Given this list of marker genes PTGER4, FLT4, ULK4, IRAK4, APP, NR2C2, PAFAH1B1, LTBR, TAOK1, CRK (NCBI Gene Id 1398), EDAR, MTURN (NCBI Gene Id 222166), TNFRSF11A, TNIK, MAP4K1, MAPK9, TLR3, SH2D3A, DUSP19, MDFIC, ANKRD6, GPS1, CBS, MAP3K13, MYD88, CCL21, EDA2R, PRMT1, NFKB1, FGF12, FZD10, STRADB, NAIP, SIRPA, MAP3K6, LRRK2, GADD45G, WNT5A, CCN2, TRAF2, HRAS, GRIK2, PHLPP1, SEMA3A, MAP3K15, FKTN, MDFIC2, MYOC, MAP4K3, TAOK3, EPHA4, FZD7, CCL19, AGER, MINK1, MEN1, TLR7, EDN1, HIPK2, IRAK1, TNXB, GSTP1, MAP4K2 (mitogen-activated protein kinase kinase kinase kinase 2), MIR92A1, UNC5CL, SLAMF1, EPHB1 (EPH receptor B1), NOD2, PDCD4, DVL2, MARVELD3, TAOK2, TLR9, PTK2B, CARD9, CDC42EP5, PLCB1, WNT16 (Wnt family member 16), MAPKBP1, ZNF622, MAP2K4, TPD52L1, RASSF2, RIPK1, DUSP10, ARHGEF6, TNFRSF19, ATF2, MAPK8, BIRC7, NOX1, MDFI, ITCH, TNF, SH2D3C, MBIP, AIDA, TRAF6, SERPINB3, MAP2K7, MAPK8IP1, PINK1, NRK, CRACR2A, STK3, JUN, DACT1, PYCARD, NPPA, HIPK3, WNT7B (Wnt family member 7B), TRAF4, CCDC88C, SERPINF2, PJA2, NPHS1 (NPHS1 adhesion molecule, nephrin), HACD3, MAP1LC3A, F2RL1, MAPK10, MAP3K12, MAPK8IP3, PER1, MAP3K7, PRKN, RB1CC1, RIPK2, MFHAS1, TRPV4, DKK1 (NCBI Gene Id 22943), ERCC6, GADD45B, DUSP22, COPS5, RNF13, DAB2IP, TIRAP, IGF1R, DVL3, CD27, GADD45A, MAP3K20, XIAP, CYLD, MAP3K10, TGFBR3, FGF19, KLHL31, SH3RF2, HMGB1, DAXX, TRIB1, FCGR2B, SH3RF1, TLR4, FGF14, ZMYND11, ENSG00000274276, RAP2A, MAPK8IP2, DUSP9, DNAJA1 (NCBI Gene Id 4737), SDCBP, NCOR1, ZNF675, MECOM, PTPN22, TNFSF11, GPS2, SH3RF3, IL1B, DUSP3, CCR7, MAP3K5, CRKL, SMAD3, WNT7A, AXIN1, MAP3K11, HDAC3, CASR, MAP4K4, BECN1, NOD1, RGS2, AMBP, here is a description of the gene set: studied in species Homo sapiens Human Gene Set: GOBP_JNK_CASCADE A MAPK cascade containing at least the JNK (MAPK8) MAP kinase. It starts with the activation of JUN3K (a MAPK3K), which activates JNKK a MAP2K), which in turn activates JNK. The cascade can also contain an additional tier: the upstream MAP4K. The kinases in each tier phosphorylate and activate the kinases in the downstream tier. The JNK cascade is activated by stress signals, as well as by G protein-coupled receptors, growth factors, and cytokines, and results in cellular responses such as cell proliferation, cell differentiation, apoptosis and inflammation.